Given this list of marker genes Adrb2, Gpr88, Adra1b (adrenergic receptor, alpha 1b), Adra1d, Adra2a, Adrb3, Adra2b, Adrb1, Adra1a, Adra2c, here is a description of the gene set: studied in species Mus musculus Mouse Gene Set: GOMF_ADRENERGIC_RECEPTOR_ACTIVITY Combining with epinephrine or norepinephrine and transmitting the signal across the membrane by activating the alpha-subunit of an associated heterotrimeric G-protein complex.